The following is a description of a gene set: species: Mus musculus Mice lacking the zinc finger transcription factor specificity protein 3 (Sp3) die prenatally in the C57BL/6 background. To elucidate the cause of mortality we analyzed the potential role of Sp3 in embryonic heart development. Sp3 null hearts display defective looping at embryonic day 10.5 (E10.5), and at E14.5 the Sp3 null mutants have developed a range of severe cardiac malformations. In an attempt to position Sp3 in the cardiac developmental hierarchy, we analyzed the expression patterns of >15 marker genes in Sp3 null hearts. Expression of cardiac ankyrin repeat protein (Carp) was downregulated prematurely after E12.5, while expression of the other marker genes was not affected. Chromatin immunoprecipitation analysis revealed that Sp3 is bound to the Carp promoter region in vivo. Microarray analysis indicates that small-molecule metabolism and cell-cell interactions are the most significantly affected biological processes in E12.5 Sp3 null myocardium. Since the epicardium showed distension from the myocardium, we studied expression of Wt1, a marker for epicardial cells. Wt1 expression was diminished in epicardium-derived cells in the myocardium of Sp3 null hearts. We conclude that Sp3 is required for normal cardiac development and suggest that it has a crucial role in myocardial differentiation. Genes down-regulated in E12.5 hearts from mice with SP3 knockout compared to the wild type organ. Human Gene Set: VANLOO_SP3_TARGETS_DN from publication van Loo PF, Mahtab EA, Wisse LJ, Hou J, Grosveld F, Suske G, Philipsen S, Gittenberger-de Groot AC (PMID 17923686), and this is the list of marker genes: DNASE1L1, CD82, PITPNM1, FAH, MAOA, RABEPK, TPMT, HAVCR1, SLC39A5, UPB1, UGT2B4, NT5C3B, KHK, MARCO, RNH1, LGMN, MTHFS, CLEC10A, ITGA6, KRT8, CD5L, ADA, CAVIN3, DHRS7, SPEG, KLK8, TCF19, SP3, TOP1MT, GPR155, TOM1L1, CTSH, TAC3 (NCBI Gene Id 6866), GNG10, AQP1, PTGR1, HSD17B11, GLRX, YDJC, CDO1, GCAT, F7, CISD3, CRTAP, LEFTY1, RPP40, EVI2A, DAPK2, TXNRD3, PDZK1IP1 (PDZK1 interacting protein 1), ANXA4 (NCBI Gene Id 307), EVC, ALDOB, NME4, GPX7, IFI30, SERPINB6, CFAP57, MFSD10, NXPE2, FAM9A, NUPR1, EHHADH, QPRT, HIPK3, ACBD4, MYD88, FUOM, AKAP7, PDK1, LGALS3, MTARC1, SLC66A3, RPS6KA4, AP1S3, ZDHHC2, TM2D2, KRT20 (NCBI Gene Id 54474), CFP, LIPH, LGALS2, DHRS4, P2RX4, CD302, CAMK1, C1QB, FABP2, TSPO, IL18RAP